Given this list of marker genes Clu, Fbh1, Rps3, Cxcl12, Sirt1, Steap3, Atad5, Bcl2l1, Bcl2l12 (NCBI Gene Id 75736), Plscr1, Cdkn2d, Rpl26, Marchf7, Tmem161a, Snai1, Knl1, Kdm1a, Zfp385a, Ddias, Mtch2, Trp73, Cd44, Bid, Ell3, Hnrnpk, Snai2, Ackr3, Pias4, Tpt1, Ccar2, Muc1, Mif, Usp47 (NCBI Gene Id 74996), Skil, Rad9a, Cd74, Nacc2 (nucleus accumbens associated 2, BEN and BTB (POZ) domain containing), Triap1, Trim32, here is a description of the gene set: Any process that modulates the frequency, rate or extent of intrinsic apoptotic signaling pathway in response to DNA damage. species: Mus musculus Mouse Gene Set: GOBP_REGULATION_OF_INTRINSIC_APOPTOTIC_SIGNALING_PATHWAY_IN_RESPONSE_TO_DNA_DAMAGE